Given this list of marker genes Rnf19a, Smkr-ps, Cxcl16, Pvt1, Anp32a (acidic nuclear phosphoprotein 32 family member A), Arap1 (NCBI Gene Id 69710), Trem2, Ift20, 4933406D12Rik, Trmt1, Tmem144, Ppp1r27, Abhd14b, Lgmn, Rtraf, Man2a2, Tmem132cos, Rab2b, Ogfod2, Rnf26 (ring finger protein 26), Tpm3, Nuf2, Actg2, Klf13 (NCBI Gene Id 80528), Vhl, Nptxr, Gstz1, Grip1 (glutamate receptor interacting protein 1), Irak1, Cfap144, Krtap5-4, Bcl2a1d, Arhgap4, Rpain, Tektip1, Strap, Sod3, Clec3b, Morn5, Tex48, Ankef1, Elapor1, Ccl27a, Eml4, Ptprjos1, Nrsn1, Cx3cr1, Spp1, Tlcd3b (NCBI Gene Id 77785), Cdc42ep2 (NCBI Gene Id 68573), Chchd5, Pdp2, Ebf2, Denr, Ctsl, Gtf2e2, Acta1, Clvs1, Cited2, Map1lc3a, Gnao1, 4921517D16Rik, ENSMUSG00000136050, Foxl2, Spata31d1e, Kcnu1, Best1, Ttc9, Nit1, Fam217a, Nbn, Arl2, Sox5 (NCBI Gene Id 319649), Dip2a, Pex16, Coq8a, Pabpc4, 4930511M18Rik, Msi1 (musashi RNA-binding protein 1), Srsf1, Brf1, Zfp11, 1700123O20Rik, Rnf181, Cp, Chp1, Apoe, Ovol2, Pla2g10, Baiap2, Zfp830, Smu1, ENSMUSG00000122613, Pepd, Bmyc, Patj, Plet1, Swap70, Gtf2i, Ncan, Tyro3, Ighg1, Pacsin2, Ythdf2, Calm2, Fam178b, Otud1, H2-Q5, Ambra1, Dnajc1, Tnp2, Ccni, Acta2, Tssk6, Cct4, Apod, Bag6, Mt1, Fam186a, Mef2c, Creld1, Krt2, Asns (NCBI Gene Id 27053), Cct6b, Map2k5, Batf3, Racgap1, Sod1, 2010203P06Rik, Med17, Qprt, Rspo1, Mrps18a, Trbv5, Zfp787, Raph1 (NCBI Gene Id 77300), Phf2, Sun1, Dguok, Tsc22d4, Slc39a13, Cpa5, Lyar, 2610042L04Rik, Ltbp4, Bid, Dok4, Polr1has, Mapk8ip3, Meox2, Fam3a, 4930571K23Rik, Samhd1, Myo1a, 1700037C18Rik, Ube4b, Dctn1, Cspp1, Mycn (NCBI Gene Id 18109), Cds1, Spanxn4 (NCBI Gene Id 73309), Itpr1, Poli, Brsk2, Pkhd1, Icam1 (intercellular adhesion molecule 1), Pygo2, Rasip1, Rtn4r, Ttll11, 1110004F10Rik, Srf, Gid8, Fbrsl1, Cd248 (CD248 antigen, endosialin), 3110070M22Rik, 4930527J03Rik, Lyz2, Plac8, Gsk3b (glycogen synthase kinase 3 beta), 1700085D22Rik (NCBI Gene Id 73512), Akirin2, Smim8, Paqr7 (NCBI Gene Id 71904), Pus10, Gkn3 (gastrokine 3), Gadd45gip1, here is a description of the gene set: Mouse Gene Set: DARWICHE_PAPILLOMA_RISK_LOW_DN from publication Darwiche N, Ryscavage A, Perez-Lorenzo R, Wright L, Bae DS, Hennings H, Yuspa SH, Glick AB (PMID 17525749) Chemical induction of squamous tumors in the mouse skin induces multiple benign papillomas: high-frequency terminally benign low-risk papillomas and low-frequency high-risk papillomas, the putative precursor lesions to squamous cell carcinoma (SCC). We have compared the gene expression profile of twenty different early low- and high-risk papillomas with normal skin and SCC. Unsupervised clustering of 514 differentially expressed genes (P<0.001) showed that 9/10 high-risk papillomas clustered with SCC, while 1/10 clustered with low-risk papillomas, and this correlated with keratin markers of tumor progression. Prediction analysis for microarrays (PAM) identified genes that distinguished the two papilloma classes, and a majority of these had a similar expression pattern in both high-risk papillomas and SCC. Additional classifier algorithms generated a gene list that correctly classified unknown benign tumors as low- or high-risk concordant with promotion protocol and keratin profiling. Reduced expression of immune function genes characterized the high-risk papillomas and SCC. Immunohistochemistry confirmed reduced T-cell number in high-risk papillomas, suggesting that reduced adaptive immunity defines papillomas that progress to SCC. These results demonstrate that murine premalignant lesions can be segregated into subgroups by gene expression patterns that correlate with risk for malignant conversion, and suggest a paradigm for generating diagnostic biomarkers for human premalignant lesions with unknown individual risk for malignant conversion. studied in species Mus musculus Genes down-regulated during skin tumor progression from low risk papilloma vs normal skin.